The following is a description of a gene set: The formation of a tri-snRNP complex containing U4 and U6 (or U4atac and U6atac) snRNAs and U5 snRNAs and associated proteins. This includes reannealing of U4 and U6 (or U4atac and U6atac) snRNAs released from previous rounds of splicing to reform the U4/U6 snRNP (or U4atac/U6atac snRNP) as well as the subsequent association of the U5 snRNP with the U4/U6 snRNP (or U4atac/U6atac snRNP) to form a tri-snRNP that is ready to reassemble into another spliceosome complex. Human Gene Set: GOBP_SPLICEOSOMAL_TRI_SNRNP_COMPLEX_ASSEMBLY species: Homo sapiens, and this is the list of marker genes: AAR2 (AAR2 splicing factor), SRSF12, PRPF6, USP4, DDX20, SART3, TSSC4, RNU4-1, RNU6-9, RNU6-7, RNU5A-1, PRPF3 (pre-mRNA processing factor 3), PRPF31, RNU4-2, CD2BP2, LSM2, RNU5E-1, RNU5F-1 (RNA, U5F small nuclear 1), PRPF8, PRP4K, RNU6-1, RNU4ATAC, PRPF19, RNU5D-1, RNU6ATAC, RNU5B-1, SRSF10